Given this list of marker genes Ydjc, Gm18335, Iglj3p, 4933432I09Rik, Gm22158, P2rx6, Dgcr8, Klhl24, Gm15760 (NCBI Gene Id 100042948), Mir301b, Ess2, Top3b, Gm5768, Tssk1, Ppil2, Ppm1f, Zfp520-ps, 2510002D24Rik, Gm16139, Lztr1, Rps2-ps7, Or2m12, Eif2b5, Hic2, Or2aj5 (olfactory receptor family 2 subfamily AJ member 5), Crkl, Klhl6, Iglj1, Spag6l, Abcc5, Tbx1, Mir185, Iglj3, 4930588K23Rik, B3gnt5, Rpl31-ps12, Mrpl40, Ap2m1, Parl, Iglv2, Gm49580, Smpd4, Septin5, Or2aj6, Gm15764, Iglc4, 2010309G21Rik, Rimbp3, Tango2, Rpl26-ps4 (NCBI Gene Id 623227), Klhl22, Thap7, Rtn4r, Comt, Mir3618, Iglc2, Gm17799, Gm46540, Trmt2a, Or2l13b, A930003A15Rik, Or2l5, Vpreb1b, Tssk2, Dgcr6, Gm16618, Fam246a, Gsc2, Gm6440, Gm25777, Gm15798, Slc7a4, Map6d1, Or2l13, Dvl3, Gm25762, Bod1-ps, AA914427, 4933404G15Rik, Hira, Iglv1, Gm6048, Dgcr2, Ufd1 (NCBI Gene Id 22230), A530030E21Rik, 4930483P17Rik, Cdc45, Ube2l3, Gm18747, Txnrd2, Gm18869, Mir6366 (microRNA 6366), Zdhhc8, Ranbp1, Iglc3, Mapk1, Abcf3, Lamp3, Scarf2, Iglv3, Ccdc188, Mir1306, Med15, Igll1, Gnb1l, Vpreb1a, Or2m13, 2610318N02Rik, Or7a40, Gp1bb, Serpind1, Gm6438, Cyp2ab1, Iglj4, Ypel1 (NCBI Gene Id 93818), Aifm3, Gm10241, Mir130b (NCBI Gene Id 723816), Tmem191, Pi4ka, Sdf2l1, Snap29, Ccdc116, Cldn5, Gm10088, Iglj2, Iglc1, Or2aj4, Ccdc74a, Slc25a1, Fgd4, Lrrc74b, Gm18748 (NCBI Gene Id 100417664), Gm49566, Yeats2, Gm24927, Car15, Prodh, 1700056N10Rik, here is a description of the gene set: studied in species Mus musculus Mouse Gene Set: chr16A3